Given this list of marker genes CD2BP2, TSPAN2, PLPP3, ECHS1, SLC22A13, KCNN2, ELF2, RGS7, NEIL3, MPP2, TUBGCP4, WDR33, OFD1, FUOM, NR4A2, DECR2, UBLCP1, PHPT1, CLEC4E, TTLL1, NSG2, BMAL1, CLCN6, CENPK, ZFYVE16, RAB27A, STX18, CSRP1, SLC11A1, AQP3, RGS20, ZNF841, TAGLN3, RGS2, FAM76A, ASF1B, ACTR6, GTF3C5, OTOG, PCDHB2, ITGAE (integrin subunit alpha E), CUL4B, HAL, PBX1, GALNT10, MYO18A, NRCAM, FTH1, ITGB3BP, ABCA1, HDC, ADGRL4, KIF23, STMN1, SNTB1, CHCHD7, FAM53C, SULT1B1, FOXN4, MSRA, BCL7C, CEP89, FUT7, SPAG5, FXN, PNCK, FANCL, SESN3, CEP55, GDF5, KIFAP3, GFRA1, OCEL1, APOOL, SBK1, GSTM1, GALNT3, GHRHR, TFPI2, LRRC61, SLAMF6, EHD4, CNR2, ORM1, RBL1, PPM1D, SYNJ2, XIAP, TMEM126A, CEBPZOS, C1GALT1, MID1, KLRK1, NECAB3, DIP2B, PDCD1, SLC8A3 (NCBI Gene Id 90450), LRRIQ4, GCDH, ZNF746, WIZ, MFAP1 (microfibril associated protein 1), NNMT, CASP14, IL1B, CPNE3, PLXNC1, CLEC6A, CRYM, PPT1 (palmitoyl-protein thioesterase 1), AXL, DIO2, JPT1, IL12RB2, ZNF329, C11orf16, GLUD1, BPIFB1, PIGB, FPR2, SP110, DSCAM, PLK4 (polo like kinase 4), EEF2K, PDPN, RBM6, PHKA2, CASP1, PROZ, DNAL4 (NCBI Gene Id 10126), NUP42, ASB16, MYLK2, RGS16, ELOVL2, SNX12, HMGB3, FRYL, PAPOLG, WNT10B, ZC3H3, IRF4, NLRP6, CAPRIN2, RUNX2, GALNT4, LMNA, PTPRJ, ABCD4, PEX2, MMS22L, MLXIPL, HSPB7, ZNF124, SEMA4A, NME7, TCF7, GAD2, BPHL, SMARCD1, WDHD1, TCP11, GP1BB, PCBP3, CEP70, MSL1, LBH, SMAD1, STAB2, NOSIP, UBE2C, STYX, PKDCC, DGLUCY, HTR6, SAA1, ALPK2 (alpha kinase 2), SLC25A35, STX17, TTR, SLAIN2, MX2, TBC1D17, IL36A, SH2D1A, MECP2, CD2, SEMA6D, CXCL3, RACGAP1, AKIP1, SLC15A2, RGS6, PHF20L1 (NCBI Gene Id 84165), MAD2L1, ZBTB14 (NCBI Gene Id 7541), ZIC2, LRRC56, NFATC2IP, CTNNA2 (catenin alpha 2), here is a description of the gene set: Genes down-regulated in KLRG1 low CD8 T effector cells during infection: wildtype versus ID2 and BCL2L11 knockout. studied in species Homo sapiens CD8+ T cells play a crucial role in the clearance of intracellular pathogens through the generation of cytotoxic effector cells that eliminate infected cells and long-lived memory cells that provide enhanced protection against reinfection. We have previously shown that the inhibitor of E protein transcription factors, Id2, is necessary for accumulation of effector and memory CD8+ T cells during infection. Here we show that CD8+ T cells lacking Id2 did not generate a robust terminally-differentiated KLRG1hi effector population, but displayed a cell-surface phenotype and cytokine profile consistent with memory precursors, raising the question as to whether loss of Id2 impairs the differentiation and/or survival of effector-memory cells. We found that deletion of Bim rescued Id2-deficient CD8+ cell survival during infection. However, the dramatic reduction in KLRG1hi cells caused by loss of Id2 remained in the absence of Bim, such that Id2/Bim double-deficient cells form an exclusively KLRG1loCD127hi memory precursor population. Thus we describe a role for Id2 in both the survival and differentation of normal CD8+ effector and memory populations. Human Gene Set: GSE41978_WT_VS_ID2_KO_AND_BIM_KO_KLRG1_LOW_EFFECTOR_CD8_TCELL_DN from publication Knell J, Best JA, Lind NA, Yang E, D'Cruz LM, Goldrath AW (PMID 23325888)